Given this list of marker genes CREBL2, RESF1, TMEM64, AP1S2, AMPD3, BCL6, POU2AF1, CXCL13, TEFM, CD84, PITPNC1, CHI3L2 (chitinase 3 like 2), SLC35F5, ACTR3, LPP, GTF2H2C, ETS1, TBC1D4, UTP3, IQGAP1, MFSD6, ZMAT3 (NCBI Gene Id 64393), HPRT1, KSR2, NCKAP1, UBTD2, STK39, PWAR5, KLHL6, ZNF518A, RUFY1, ERMP1, GET1, TOX, MYH10, EGR2, SLC25A46, CHGB, STAU2, MAN1A1, DNAJB6, ANKRD11, STAMBP, WDR11, PAWR, PUDP, OSTM1 (osteoclastogenesis associated transmembrane protein 1), CASD1, ST8SIA4, MDM4, TMBIM4, LZTFL1, ZNF638, STAT1, PON2, PPP3CB, PPP1CC (NCBI Gene Id 5501), SH2D1A, CPSF2, PHACTR2, PTPN14, GIMAP4, PRPF38B, PRKACB, here is a description of the gene set: studied in species Homo sapiens from publication Kim CH, Lim HW, Kim JR, Rott L, Hillsamer P, Butcher EC (PMID 15213097) Human Gene Set: KIM_GERMINAL_CENTER_T_HELPER_UP Gene expression profiling was used to compare the gene expression patterns of human germinal center (GC) T helper (Th) cells with other CD4+ T-cell subsets (naive, central, and effector memory T cells). GC-Th cells, specifically localized in germinal centers to help B cells, are distantly related to central and effector memory T cells in global gene expression profiles. GC-Th cells displayed substantial differences in mRNA for adhesion molecules, chemoattractant receptors, and cytokines compared with other populations. Distinct expression of transcriptional factors by GC-Th cells is consistent with the hypothesis that they may be different from other T cells in cell lineage. Interestingly, CXCL13, a critical chemokine for B-cell entry to lymphoid follicles, is one of the most highly up-regulated genes in GC-Th cells. GC-Th cells (but not other T cells) produce and secrete large amounts of functional CXCL13 upon T-cell receptor activation, a process that is dependent on costimulation, requires translation and transcription, and is dramatically enhanced by activation in the presence of GC-B cells. This study revealed for the first time the unique gene expression program of GC-Th cells. Genes up-regulated in germinal center T helper cells compared to other CD4+ T lymphocyte types.